Given this list of marker genes SUPT7L, TBC1D15, UBE2D1, TCIM, ECE1, PTP4A3, PROM1, here is a description of the gene set: species: Homo sapiens from publication Gao S, Yan L, Wang R, Li J, Yong J, Zhou X, Wei Y, Wu X, Wang X, Fan X, Yan J, Zhi X, Gao Y, Guo H, Jin X, Wang W, Mao Y, Wang F, Wen L, Fu W, Ge H, Qiao J, Tang F (PMID 29802404) Human Gene Set: GAO_STOMACH_24W_C2_TFF2POS_MULTIPOTENT_PROGENITOR